Given this list of marker genes HS2ST1, FGFR2, NSD2, STEEP1, TWIST1, FGFR3, DHX30, here is a description of the gene set: Prominent crus of helix The presence of an abnormally prominent of the crus of the helix. That is, development of the crus helix to the same degree as an average antihelix stem or helix. species: Homo sapiens Human Gene Set: HP_PROMINENT_CRUS_OF_HELIX